The following is a description of a gene set: species: Homo sapiens Human Gene Set: GSE21360_NAIVE_VS_TERTIARY_MEMORY_CD8_TCELL_UP from publication Wirth TC, Xue HH, Rai D, Sabel JT, Bair T, Harty JT, Badovinac VP (PMID 20619696) Genes up-regulated in CD8 T cells: naïve versus 3' memory. The transcriptome of naive OT-I T cells was compared to memory CD8 T cells after 1, 2, 3, or 4 infection with ovalbumin expressing Listeria monocytogenes (LM-OVA)., and this is the list of marker genes: ATOSB, MXD3, TPST1, COLQ, VRTN, PABPC3, EFS, PPP6C, CNN2, CERK, ACO1, DHRS3, SF3A3, PRDX2, ORAI3, ADORA2B, CRYL1, SMARCD1, SMYD3, CD34, GOT2, PTTG3P, TACC1, NCR3, SERF2, UBE4B, CABIN1, PCIF1, CYP26A1, ALOX5, KCNK15, HAS1, FHL1, TSKS, CENPF, KLHDC2, TCP11, ACSL5, ARPC4, GIPC1, COL19A1, TPT1, HDAC1, FLII, SPINT2, HMGB3P1, MKNK2, REPIN1, UBASH3A, SLC47A1, GATD3, RASSF2 (NCBI Gene Id 9770), TES, CBX7, TGM5, SIT1 (signaling threshold regulating transmembrane adaptor 1), UPK3A, DBN1, CHRNA10, H4C11, LASP1, GTSE1, DNAJC4, IMPDH2, OXA1L, RHOF, CDKN3, PRKCA, ANAPC15, APOC2, C2CD2, SUOX, LSM12, EEIG1, UBE2C, IFT25, ADAM29, AKR1A1, SUN2, DMBT1, CMC4, MAPK8IP2 (NCBI Gene Id 51748), LTB, BEAN1, ARB2A, ACP6, PMM1, RGL2, WAS, MYH10, ANKRD28, RPA3, TIMP2, DHX9-AS1, PATJ, AURKA (NCBI Gene Id 8465), CIDEB, TMOD2, RNF44, DCHS1 (dachsous cadherin-related 1), NDRG3, P2RX6, IRF2BP1, NF2, CYP4F2, NHERF1, RGS10, SLC2A4RG, LIPG, MAP1LC3B, LDOC1, CD68, PRKCH, TGM3, DOCK2, POTEKP, REG3A, SEC14L1, ATP2B2, GRIN2D, GRIK5, PADI3, HSPA6, PC, GDPD5, CIC, GUCY1B2, MAGEB3, ATXN2L, MMP25, IDH2, HAND2-AS1, SLC23A2 (NCBI Gene Id 9962), GPX4, RCN2, TRAF5, RAB33A, SSR2, COTL1, RRAGD, CRYBB2, CCDC33, GPR21, ARHGAP1, NANS, SPCS3, TMA7, TROAP, PKMYT1, LAIR1, CLCA2, OCEL1, FAM120A, ATP5ME, CHST1, RGS14, VAMP1, TUBA4A, AKAP8, SPAG5, CCNI, CNOT9, RASL11B, EXOC3, RAMP1, LAPTM5, ZHX3, PGC, KCNJ9, RPL10, ZNF318, AKR7A3, TNNI3, NRGN, ADD1, AKR1B1, RPL27, ARFRP1, RPL13, PTTG1, GMPPB, UNC119B, TBC1D2, ESYT1, LCP1, ZBTB7A, MACROH2A1 (macroH2A.1 histone), ARL2BP, HAUS5, ELK1, ZNF385D, VIL1, VAT1, CCNB2, FTO, EGR4